Given this list of marker genes SLC35B4, SLC35A3, SLC35D2, SLC35D1, TMEM241, here is a description of the gene set: The process in which UDP-N-acetylglucosamine is transported across a membrane. Human Gene Set: GOBP_UDP_N_ACETYLGLUCOSAMINE_TRANSMEMBRANE_TRANSPORT studied in species Homo sapiens